The following is a description of a gene set: Human Gene Set: HP_SCALP_TENDERNESS studied in species Homo sapiens Scalp tenderness Pain or discomfort of the scalp elicited by palpation., and this is the list of marker genes: HLA-DRB1, HLA-B, PTPN22, ALX4, FAS, MSX2, P4HA2